Given this list of marker genes RBL2, MAPK10, DVL3, TP73, MLKL, TCF7L1, BAD, CDKN2A (NCBI Gene Id 1029), PIK3R3, ATM, RAC1, WNT3, RAC2, WNT3A, BBC3 (NCBI Gene Id 27113), RHOA, CTNNB1, RAC3, FASLG, MDM2, PDK1, TCF7L2 (NCBI Gene Id 6934), PIK3C2A (NCBI Gene Id 5286), BAX, WNT10A, TGFB1, CDC42, SMAD3, INSR, WNT1, WNT10B, PPP2R5E, PIK3C2B, BAK1, WNT11, WNT16, JUN, MAP3K1, PIK3CB, SCP2, FOSL1, TP53, FRAT1, AXIN1 (NCBI Gene Id 8312), FOXO3, BCL2, CCND2, PIK3CA (phosphatidylinositol-4,5-bisphosphate 3-kinase catalytic subunit alpha), MAP3K7, SOD2, CAT, PIK3C3, HMGB1, CCNG2, LEF1, WNT7B, MAPK9, GRB2, IRS1, AKT3, LDLR, PIK3R5, MAPK1, WNT5A, CDKN1A, WNT7A, MYC, PIK3CD, PLAU, BCL6, AKT1, AKT2, PIK3R2, SOS1 (SOS Ras/Rac guanine nucleotide exchange factor 1), PIK3CG (NCBI Gene Id 5294), BCL2L11, APC, HRAS, ABL1, PCK2, MAPK8, KRAS, PIK3R1, BIK, PIK3R4, DVL1, TCF7, NFKB1, DVL2, PTEN, SMAD4, NRAS, G6PC1, PPP2R5C, MAP3K4, NFKB2, ERBB2, GSK3B, WNT6, CCND3, CDKN1B, WNT2B, SOS2, CCND1, PIK3C2G, WNT5B (NCBI Gene Id 84728), WNT2, WNT4, PMAIP1, SHC1, here is a description of the gene set: DNA damage response (only ATM dependent) studied in species Homo sapiens Human Gene Set: WP_DNA_DAMAGE_RESPONSE_ONLY_ATM_DEPENDENT